The following is a description of a gene set: A G protein-coupled receptor signaling pathway in which the signal is transmitted via the inhibition of adenylyl cyclase activity and a subsequent decrease in the intracellular concentration of cyclic AMP (cAMP). Mouse Gene Set: GOBP_ADENYLATE_CYCLASE_INHIBITING_G_PROTEIN_COUPLED_RECEPTOR_SIGNALING_PATHWAY studied in species Mus musculus, and this is the list of marker genes: Htr4, Grik3, Adora1, Hrh3, Oprk1, Psap, Drd3, Casr, Htr1a, Htr1b, Flna, Psapl1, Mtnr1a, Prmt5, App, Ric8a, P2ry12, S1pr3, Fpr-rs6, Grm6, Rgs2, Edn1, Gpr37l1, Gpr146, Oprd1, Gpr37, Akap12, Hrh4, Gabbr2, Gnaz (guanine nucleotide binding protein, alpha z subunit), Ednra, Adcy5, Gpr176, Grm2, Cort, Sstr2, Fpr-rs7, Oprl1, Gabbr1, Lpar1 (lysophosphatidic acid receptor 1), Chrm3, Oprm1, Gnai1, Grm4, Grm8, Htr5a, Grm3, Sstr5, Npb, Adra2a, Htr1d, Fpr-rs3, Npy2r, Gnai2, Fshr, Aplnr, Fpr-rs4, Drd2, P2ry1, Insl3, Palm, Chrm2, Drd4, Htr1f, Ffar3, Rxfp2, Taar1, Chrm4, S1pr1, Ptger4, Gnao1, Grm7, Gnai3, Prkaca, Chrm5, Pde2a, Fpr2 (formyl peptide receptor 2), Npr3, Marco, Itgb3, Chrm1, Akap5, Ptgdr2 (NCBI Gene Id 14764), Htr5b